Given this list of marker genes Slc8a3, Disc1, Mcur1, Afg3l2, 1600014C10Rik, Prkce, Micu3, Atp2a1, Pdzd8, Micu2, Slc25a27, Bnip3, Tgm2, Slc8b1, Letmd1, Maip1, Letm1, Anxa6, Immt, Smdt1, Nol3, Rap1gds1, Mcub, Mcu, Fate1, Slc25a23, Mfn2, Micu1, here is a description of the gene set: species: Mus musculus Any process involved in the maintenance of an internal steady state of calcium ions within the cytoplasm of a cell or between mitochondria and their surroundings. Mouse Gene Set: GOBP_MITOCHONDRIAL_CALCIUM_ION_HOMEOSTASIS